The following is a description of a gene set: from publication Durant L, Watford WT, Ramos HL, Laurence A, Vahedi G, Wei L, Takahashi H, Sun HW, Kanno Y, Powrie F, O'Shea JJ (PMID 20493732) studied in species Homo sapiens Genes up-regulated in CD4 T cells treated with IL6: STAT3 knockout versus wildtype. Human Gene Set: GSE21670_STAT3_KO_VS_WT_CD4_TCELL_IL6_TREATED_UP STAT3, an essential transcription factor with pleiotropic functions, plays critical roles in the pathogenesis of autoimmunity. Despite recent data linking STAT3 with inflammatory bowel disease, exactly how it contributes to chronic intestinal inflammation is not known. Using a T cell transfer model of colitis we found that STAT3 expression in T cells was essential for the induction of both colitis and systemic inflammation. STAT3 was critical in modulating the balance of T helper 17 (Th17) and regulatory T (Treg) cells, as well as in promoting CD4+ T cell proliferation. We used chromatin immunoprecipitation and massive parallel sequencing (ChIP-Seq) to define the genome-wide targets of STAT3 in CD4+ T cells. We found that STAT3 bound to multiple genes involved in Th17 cell differentiation, cell activation, proliferation and survival, regulating both expression and epigenetic modifications. Thus, STAT3 orchestrates multiple critical aspects of T cell function in inflammation and homeostasis., and this is the list of marker genes: MSANTD2, MOB1A, DEPDC7 (NCBI Gene Id 91614), DCX, HNMT, LAIR1 (NCBI Gene Id 3903), IL1RL2, RGCC, TXNDC5, FAM111A, LIPE, GORASP2, DMKN, KIF13A, PCYOX1L, S100A8, SNED1, REEP1, EPS15L1, RTKN, XDH, LEMD1, MANBA, PLOD3, CAMKMT, STK26, LPL, RENBP, RNASET2, NIN (NCBI Gene Id 57681), DUBR, CSDE1, ARL10, SCCPDH, RFC1, PTER, PPFIBP1, NID2, SLC36A4, FCGR2A, SLFN12, OSER1, PRKCI, OXR1, DDOST, SNX7, PLCB1, TXNDC11, G6PD, MGAM, RIPK3, CYRIB, ZHX1, RASA3, GLRX, LCN2, BPNT1, ACAD8, GALNS, PRRC1, RNF130, TMEM26, ATG12, SUPT3H, TMEM170B, MTSS2, PIWIL2, ATP11A, PROM1, UBTD2, RNF149, OR52N4, CCDC63, LTA4H, SDF2L1, DGKG, PDE4DIP (phosphodiesterase 4D interacting protein), ADGRE1, PEPD, EHD4, TMX4, TMEM174, LCP2, SYCE2, ZNF420, DYNLT5, FLNA, SRPK3, ISCU, CLEC7A, MAOA, B4GALT1, SLC22A4, CD70, SLC28A2, SRD5A3, LINGO1, PAPSS2, GNG12, TMEM38B, KCNE3, SLAIN2, PTGS1, NECAP1, GDE1, TTC33, ATF6, SPTLC2, TMEM50A, NRG1, TMX3, G0S2, SGMS2, TMED4, NAGPA, TOP3B, GAMT, FKBP3, KCTD20, AIM2, POC1B, RAB9A, IRAK3, GAS7, GOSR1, RND3, OLR1 (oxidized low density lipoprotein receptor 1), F10, TRAM1L1, PFKP, DNAJC3 (DnaJ heat shock protein family (Hsp40) member C3), RASSF3, SOWAHC (sosondowah ankyrin repeat domain family member C), MSRB1, RFLNB, GGH, GOSR2, UGDH, NUDT7, TLX1, SERP1, BMX, RAB21, RPS6KA3, ANKRD10, PRDX5, KIFAP3, TASL (TLR adaptor interacting with endolysosomal SLC15A4), SYNC, CLDN15, DAB2, UBE2A, TENT2, PHYH, RNF13, PDS5B, PSTPIP2, B4GALT4, C3, ESYT1 (extended synaptotagmin 1), ARF1, FIG4, KLF12, ACAP2 (NCBI Gene Id 23527), LRRC26, TXNDC12, ZBTB34, TTC32, CFLAR, CLEC4A, SLC7A2, KYAT3, ADGRA3, RTN3, OTOA, CLK2, LMAN1L, ETHE1, TSPAN31, MLKL, SDF4, PLD1, CSF2, EFR3A, TRIM17, ANKRD28, GALK2, LAMP1 (lysosomal associated membrane protein 1), SPACA1, TAF13, SVIP, AP3S1, ADAM9, DCUN1D4, ALAS1 (5'-aminolevulinate synthase 1), GCA, EHMT1, SIAH2, AGPS, RNF4